Given this list of marker genes CAMK1D, IL23A, RTN4, JAM3, LGALS3, SAA1, TREM1, PRTN3, ITGA9, SLIT2, JAML, VAV1, FUT4, PERP, XG, PLA2G1B, PIP5K1C, BST1, NCKAP1L, SLAMF8, ADAM8 (ADAM metallopeptidase domain 8), CCL28, FCER1G, PDE4B, GBF1, CXCR1, MIR223, CXCL10, SELENOK, CD99, JAGN1, EDN1, CKLF, S100A8, CD99L2, PF4, PIK3CD (phosphatidylinositol-4,5-bisphosphate 3-kinase catalytic subunit delta), EMP2, CX3CL1, CXCL5, CXCL6, C1QBP, CSF3R, PECAM1, CXCL13, CXCL3, TGFB2, THBS4, CCR7, CCL3, CD177, PIK3CG, VAV3 (NCBI Gene Id 10451), MCU, IL1R1, FUT7, GP2, CD300H (NCBI Gene Id 100130520), SRP54, MOSPD2, RAC1, DPP4, EDN2, EDN3, MDK, CXADR, CCL27, RIPOR2, DPEP1, CCL21, PIKFYVE, ITGB2, ITGA1, CCL19, IRAK4, PPIB, S100A9, BSG, LBP, MCOLN2, C5AR2, IL1B, S100A12, SYK, PPBP, PF4V1, DNM1L, CXCL9, TIRAP, MYD88, CXCL8, MPP1, C5AR1, PPIA, UMOD, FAM3D, RAC3, CD74, CXCR2, TNFAIP6, PREX1, C3AR1, WDR1, RAC2, DAPK2 (death associated protein kinase 2), XCL1, here is a description of the gene set: The movement of a neutrophil within or between different tissues and organs of the body. Human Gene Set: GOBP_NEUTROPHIL_MIGRATION species: Homo sapiens